The following is a description of a gene set: Myeloid dendritic cells (DC) and macrophages play an important role in pathogen sensing and antimicrobial defense. Recently we demonstrated that infection of human DC with intracellular bacterium Listeria monocytogenes (L.monocytogenes) leads to the induction of the immunoinhibitory enzyme indoleamine 2,3-dioxygenase (Popov et al., J Clin Invest, 2006), while in the previous studies L.monocytogenes infection was associated with a rather stimulatory DC phenotype. To clarify this discrepancy we performed comparative microarray analysis of immature mo-DC (immDC), mature stimulatory mo-DC (matDC) and mature inhibitory DC either stimulated with prostaglandin E2 (PGE2-DC) or infected with L.monocytogenes (infDC). Studying infection of human myeloid DC with Listeria monocytogenes, we found out, that infected DC are modified by the pathogen to express multiple inhibitory molecules, including indoleamine 2,3-dioxygenase (IDO), cyclooxygenase-2, interleukin 10 and CD25, which acts on DC as IL-2 scavenger. All these inhibitory molecules, expressed on regulatory DC (DCreg), are strictly TNF-dependent and are in concert suppressing T-cell responses. Moreover, only DCreg can efficiently control the number of intracellular listeria, mostly by IDO-mediated mechanisms and by other factors, remaining to be identified. Analyzing publicly acessible data of transcriptional changes in DC and macrophages, infected by various pathogens and parasites (GEO, GSE360), we noticed that infection of these cells with Mycobacterium tuberculosis causes transcriptional response, comparable with the one caused by listeria in human DC. In fact, granuloma in tuberculosis and listeriosis in vivo are enriched for myeloid DC and macrophages characterized by regulatory phenotype. In summary, regulatory myeloid DC and macrophages may play a dual role during life-threatening granulomatous infections, such as tuberculosis: on one hand, regulatory myeloid cells promote pathogen containment by efficiently killing intracellular bacteria, on the other hand these cells inhibit granuloma-associated T cells and thereby might be involved in the retention of TNF-controlled granuloma integrity protecting the host from granuloma break-down and pathogen dissemination. species: Homo sapiens Human Gene Set: GSE9946_IMMATURE_VS_MATURE_STIMULATORY_DC_DN from publication Popov A, Driesen J, Abdullah Z, Wickenhauser C, Beyer M, Debey-Pascher S, Saric T, Kummer S, Takikawa O, Domann E, Chakraborty T, Krönke M, Utermöhlen O, Schultze JL (PMID 18802101) Genes down-regulated in dendritic cells: immature versus mature stimulatory., and this is the list of marker genes: PLA2G2D, MIR455, TMEM82 (transmembrane protein 82), JAG1, GP2, SCTR, PRDM13, GNG8, EGFR, EPM2A, PCDHB1, GLIPR1L2, SPATA7, RAP2A, KCNAB1, PPP6R1, TARM1, PRSS3 (serine protease 3), SIGLEC1, IL2RA, BCAP29, FAM178B, ARL9, FOXI1, TOMM20L (NCBI Gene Id 387990), PDHA2, PTH2, THAP12, DIO1, FOLH1 (folate hydrolase 1), PLA2R1, RTKN, PSMB11, TRIM72, KCNT1, LRRC7, TRIM50 (NCBI Gene Id 260316), CACNG5, SEC16B, PSD, FAM187B, GADL1, CER1, RAB39A, TMEFF2, KREMEN2, TMEM35A, WWTR1, TMX1, GABRD, SIX4, FBXO4, TPD52, FGG, HSD3B2, CAVIN1, PKHD1, MIR448, CNTNAP4, LFNG, RGS9, ACTRT3, KLHL23, CTHRC1, TNFAIP6, COLGALT2, PBLD, S100A8, MIR20A, PLB1, CSMD3, LGI2, LRIG3, ST18, FBXO39, MYO1D, NR1H5P, HTR1A, ME1, FKRP, LCLAT1, VLDLR, CDH7, ARHGEF5, TREML4, ADGRG5, BICC1, ACE, ELL2, TMEM217, SCN11A, CDR2L, SFXN2, MYOF, MOCS3, TNMD, MICAL2, HOXB3 (NCBI Gene Id 3213), FTO, NMBR, SDC4, HDGFL1, TMEM165, FOXB2, PRL, ACE2, HOXC6 (NCBI Gene Id 3223), MOGAT2, EDA, CLEC7A, DYDC1, DIXDC1, SLC12A5, OPN3, GJB5, MEP1B, PRSS33, TRIM40, CHST1, LELP1, POU4F1, MIR139, KRT16, KCNK12, FREM2, GPR161, ANPEP, LRTM2, KCNC3, KHDRBS3, MSR1, MYO16, NT5C1B, FMNL2, THNSL2, CES4A (NCBI Gene Id 283848), HEBP1